The following is a description of a gene set: species: Mus musculus Any process that modulates the frequency, rate or extent of the assembly of a filopodium, a thin, stiff protrusion extended by the leading edge of a motile cell such as a crawling fibroblast or amoeba, or an axonal growth cone. Mouse Gene Set: GOBP_REGULATION_OF_FILOPODIUM_ASSEMBLY, and this is the list of marker genes: Ccl21d, Ccl21f, Plppr5, Ccl21a, Trpm2, Mien1, Nrp1, Dbn1, Ppp1r9a, Tenm2, Ripor2, Tenm1, Ccl21b, Rala, Nlgn1 (neuroligin 1), Prkcd, Rab3ip, Fscn1, Arap1, Arpc2, Dmtn, Ccl21e, Daam2, Fmr1, Palm, Agrn, Stau2, Rac1, Fnbp1l, Gap43, Gpm6a, Espn, Arf6, Tgfbr1, Pik3r1, Myo10, Ccr7, Dock11, Wasl, Capzb, Dnm3, Actr3, Rab5a, Myo3a, Cdc42, Rab17, Myo3b, Neurl1a, Rhoq, Tgfb3, Ephb2, Arhgap44, Zmynd8, Cln3, Dpysl3, Ppp1r16b, Nrxn1, Prkcq, Abitram, Srf